Given this list of marker genes Notch4, Notch1, Notch3, Tmed2, Prkci, Elf3, Furin, here is a description of the gene set: species: Mus musculus Mouse Gene Set: REACTOME_PRE_NOTCH_EXPRESSION_AND_PROCESSING Pre-NOTCH Expression and Processing